Given this list of marker genes HACE1, LMO1, PHOX2B, LIN28B, MYCN, ALK, here is a description of the gene set: Human Gene Set: HP_ANTALGIC_GAIT Antalgic gait species: Homo sapiens To avoid pain weight is put on the affected leg for as short a time as possible, resulting in a limp. The patients appear to be walking as if there were a thorn in the sole of the foot. To reduce the load on the affected leg the patients lift and lower their foot in a fixed ankle position.